Given this list of marker genes HRK, NPVF, KRT75, SLCO2B1, SLITRK3, YWHAG, TMEM178A, ROR1, NREP, MBD5, TEAD1, CCDC148, PRX, AVP, PDE1C, SND1, MRPS18B, GPAA1, RABGAP1L, ARL2BP, MAG, MYH8, RBP5, WRN, SCML4, RYBP, CLEC3A, RNF213, BEST3, ANKRD23, CYB5R4, CTCF, HLA-DQB2, STMN4, PRKCQ, WNT7A, LEAP2, HEBP1, CUL7, CRYBA1, FGF7, HELZ2, GNG10, APH1A, DDX3X, PPEF2, METAP1, INPP4B, LINC00305, PPP1R15A, EVA1B, HTR2B, DNASE2B (deoxyribonuclease 2 beta), FUT11, SEMA4B, WDR81, SENP1, ATXN7L2, IRS1, RUNX1, PTPRN, SLC30A8, PADI4, PPP1R16B, FAM110A, ASIC1, CPXM1, ZNF503, ARHGAP24, AP1G1, NCKIPSD, PLEKHH3, JARID2 (jumonji and AT-rich interaction domain containing 2), PPP1R10 (NCBI Gene Id 5514), LYVE1, DIAPH1, RANBP9, GSTA2, DNAJC11, ZNF462, UCN2, KCNK12, NEXN, RBM15B, SON, HIVEP3, TOB1, FES, ETV5, OMG, DIO3, LRMDA, STIM1, SLC9A9, SPATA3, SPOCK2, GPR157, USP2, STAB1, TIMD4 (T cell immunoglobulin and mucin domain containing 4), FAM91A1, RARA, WBP4, PURG, CDC42SE1, ASPA, PPP2R5B, FILIP1, ARIH1, ABHD17B, ZP1, GAD2, INA, ENPP2, CLC, RAB30, PAQR4, C9orf85, FAM124A, PITPNC1, PREB, UNC45A, SIX1, ITPR3, MEIS2, CACNG3, TCF4, CACNA1B, CAMK2A, DNAJC18, ELAVL2, SLA2 (Src like adaptor 2), LDB1, CTNND1, MYL1, SLC5A3, LDLRAD3, DNMT3A, MLLT11, SYT5, OSR1, PAX2, AMELX, WDFY3, DTNB, PKN1, CLSTN3, FOXP2, TUB, DICER1, AIF1, PFKFB3, TFAP2D (NCBI Gene Id 83741), TRIB2, RNF43 (NCBI Gene Id 54894), THAP11, COL19A1, GPBP1, IL4, ADGRB2, AGAP3, TANGO2, NLN, NR3C2, GPR173, JMJD1C, RHOBTB2, FOS, PLEC (plectin), NCDN, FBXL19, CNTLN, CYBC1, ZBTB5, MYB, LMO3, P2RY10, RPL28, ZNF217, TRIM2, SLC7A2, OLFML2A, ADCYAP1, TMEM62, SLC16A6, DNAJB4, SLC6A2, SPATS2, LCK, CALHM5, ASB9, ESRRB, PSMD11, SLCO1C1, WDR86, TYRO3, CA10, TAAR9, RLBP1, CARMIL1, NRG1, CALM3, TBC1D10B, MIDEAS, IL9, PTPRG, HSCB, KRT16, KDM2A, SEZ6, PLBD2, C1orf21, NHLH1, HOXB9, STAG2, PTOV1, IL17RC, LRRN1, ANKRD13D, MYLK, CEACAM1, SLC6A14, GABRA6, UBQLN2, PRDM1, HSPA5, NDST2, APOH, STON2, RAB1A, RARB, PCSK1, H2BC11, GALNT13, NAV2, NRP2, PSMD3, RAB5B, GABBR1, HS6ST2, MIR22HG, MED13, PLAG1, DCTN3 (dynactin subunit 3), HHEX, FNDC9, PCYOX1L, LRRK1, IQSEC1, SIAH3, SPOP (NCBI Gene Id 8405), GALNT10 (NCBI Gene Id 79615), RHOG, SRCAP, ETV1, UBE2D1, CYP17A1, DDIT3, SLITRK6, DTNA (dystrobrevin alpha), ERH, NDUFA4L2, ITGA3, RUNX1T1, IL23R, IGFBP6 (insulin like growth factor binding protein 6), ZNF532, URI1, NRP1, MXI1, ISCU, TAB2, MGAT4C, CGGBP1, AXIN2, KCND3, PKP4, MYLK3, CHI3L1, OTX2, COL1A2, SGTB, KCNQ4, MC4R, PCF11, MITF, TCF21, PLAU (NCBI Gene Id 95176), ARMCX2, TEK, BRINP3, LMO4, DOK4, BTAF1, CACNA1E, PTGS1, SLC31A2, AMY2A, MYOC, FRMD5, JPH2, TRIOBP, H2AC11, LCTL, TRAF4, PCBP4, USP16, TIGD4, NAT8L, SLC25A51, MAP4 (NCBI Gene Id 4134), TPM4, ZFY, GPR119, MSX2, RNF152, FGF13, ACTL6B, ANGPT1, AMELY, VCPKMT, FSIP2, SUPT16H, MAPK12, TLCD3B, PPP2R5C, PPP2R2B, GPR63, LRRTM4, BNC2, MAP3K15, LINC02687, SNX15, FGF6, SLIT3, DHRS3, ABI3BP, FGF9, SNCB (synuclein beta), NAPA, CHPF, ZNF516-DT, SHANK1, P2RX6, RP1, DLC1, LHFPL1, SNX10, WNT8B, HOXA3, DTX2, SLC39A13, CKM, SLITRK1, TMEM71, INTS2, NKX2-1, SAMD7, ADARB2, GADD45A, POU3F4, BMP2, SYNCRIP, VPS16, PPP2CA (NCBI Gene Id 5515), VGLL4, HECTD1 (NCBI Gene Id 25831), SRRM2, KCNA1, MOAP1, NUFIP2, UBA3, CNTN6, NR4A1, TSC22D3, BUB3, DHFR2, ULK1, HHATL (hedgehog acyltransferase like), RHBDD3, ITPRIPL1, GPR85, GJA1, TTN, BRD2, PPM1E, LMOD1, F5, RYR1, NECTIN3, GPR21, ZNF654, MICAL1, SKAP1, RTN4R, FBXO11, ARHGEF19, PRUNE1, SLC43A2, FYN, PTPRA, CACNG2, GLT8D2, ARFIP1, CPNE1, DRP2, CYTOR, COL5A3, TNXB, ZHX2, ZEB2, TBL1Y, E2F3, FBXW7, ALDOA, TNPO2, SSX5, HLA-DRB1, CDK18 (cyclin dependent kinase 18), PABPC5, SSMEM1, TTR, TBL1X, CCDC80, HDDC3 (NCBI Gene Id 374659), TOMM22, CNOT3, PDE6B, PHC1, GPM6B, LINC01931, MAPK8IP2, P2RY6, MRPL24, LRATD1 (LRAT domain containing 1), SERPIND1, LGR4, PTP4A1, RGS8, DDIT4L, OPN1SW, KDM5C, SLC39A9, CSAD, CD2AP, KAT14 (NCBI Gene Id 96680), TBX2, SLC35E1, LINC02694, MAP3K13, ADNP, HLA-DRB4, CDK15 (cyclin dependent kinase 15), TMCC1, PDZRN4, C8B, BLNK, SLC26A3, PPFIA2 (PTPRF interacting protein alpha 2), GRHL3 (NCBI Gene Id 57822), STBD1, REEP6, CCDC9B, KCNV2, ANKLE1, ZNF384 (NCBI Gene Id 404213), NSUN3, PITX2, GRIN2B, DOCK8-AS1, ADAMTS4, SREBF2 (NCBI Gene Id 6721), LRATD2, WNK4, MLX (NCBI Gene Id 6945), ASB4, NTNG2, ARL4C, GDPD2, ANK3, AAK1, PCDH18, GBA2, ABCF3, ZNF593, WDFY3-AS2, MRI1, MADD, OSBPL7, GART, FER1L6-AS1, NSD1, SEMA4C, NANOS1, PRKAA2, EIF4A2, SZT2, RHOQ, MAOB, PCDHGC3, TBXAS1, SYT4, FXYD6, ACR, KCND1, ELK3, MEX3B, SMIM3, LRRC4, MOB3C, FKBP1A, SH3BGRL2, CAMSAP1, CDH10, NPHS1 (NPHS1 adhesion molecule, nephrin), SLC22A17, SSX9P, MINDY1, HSPB7, RLIM, MEPE, HNRNPA0, COX14, ARF1, CHRNB4, THRAP3, KCNH3, DGKZ, NUMBL, EWSR1, FAM219A, PIGN, SNAP25, ANKRD28 (NCBI Gene Id 23243), CCND2 (cyclin D2), KCNIP4, RRAGA, WNT2, DNAI1, WNT3, ZFPM2, CMAS, RBFOX1, MEIS1, PCDH10, RAB3C, CCDC91, here is a description of the gene set: studied in species Homo sapiens Comprehensive identification of all functional elements encoded in the human genome is a fundamental need in biomedical research. Here, we present a comparative analysis of the human, mouse, rat and dog genomes to create a systematic catalogue of common regulatory motifs in promoters and 3' untranslated regions (3' UTRs). The promoter analysis yields 174 candidate motifs, including most previously known transcription-factor binding sites and 105 new motifs. The 3'-UTR analysis yields 106 motifs likely to be involved in post-transcriptional regulation. Nearly one-half are associated with microRNAs (miRNAs), leading to the discovery of many new miRNA genes and their likely target genes. Our results suggest that previous estimates of the number of human miRNA genes were low, and that miRNAs regulate at least 20% of human genes. The overall results provide a systematic view of gene regulation in the human, which will be refined as additional mammalian genomes become available. Genes having at least one occurrence of the highly conserved motif M92 TGCTGAY in the regions spanning 4 kb centered on their transcription starting sites. The motif does not match any known transcription factor binding site. Human Gene Set: TGCTGAY_UNKNOWN from publication Xie X, Lu J, Kulbokas EJ, Golub TR, Mootha V, Lindblad-Toh K, Lander ES, Kellis M (PMID 15735639)